Given this list of marker genes UNC13A, PRPH, HNRNPA1, GRIN2A, CASR, OPTN, MATR3, PRNP, PON2, ANXA11, ANG, SQSTM1, TBK1, NEK1, BTD, ASAH1, TARDBP, GLE1, SRPX2, PON1, GLT8D1, CFAP410, TAF15, VCP, DAO, NEFH, SOD1, PPARGC1A, SCN4A, UBQLN2, ATXN2, BRF1, TAF1, TREM2, CCNF, GABRG2, CHMP2B, FIG4, FUS, GBA1, VAPB, TSPYL1, PLP1, ERBB4, PON3, UBE3B, PFN1, DCTN1, CHCHD10, here is a description of the gene set: Abnormal larynx physiology studied in species Homo sapiens Any anomaly of the function of the larynx. Human Gene Set: HP_ABNORMAL_LARYNX_PHYSIOLOGY